Given this list of marker genes GANAB, SLC22A12, PKD1, PKD2, APRT, ALG9, PRPS1, ALG5 (ALG5 dolichyl-phosphate beta-glucosyltransferase), BICC1, IFT140, HPRT1, SLC2A9, DNAJB11, here is a description of the gene set: Uric acid nephrolithiasis studied in species Homo sapiens Human Gene Set: HP_URIC_ACID_NEPHROLITHIASIS The presence of uric acid-containing calculi (stones) in the kidneys.